Given this list of marker genes ACOX2, CRAT, ACOXL, ACOX1, ACAA1, ACOX3, here is a description of the gene set: Human Gene Set: GOMF_ACYL_COA_OXIDASE_ACTIVITY studied in species Homo sapiens Catalysis of the reaction: a 2,3-saturated acyl-CoA + O2 = a (2E)-enoyl-CoA + H2O2.